The following is a description of a gene set: species: Mus musculus Any process that modulates the frequency, rate or extent of the chemical reactions and pathways resulting in the formation of glycogen. Mouse Gene Set: GOBP_REGULATION_OF_GLYCOGEN_BIOSYNTHETIC_PROCESS, and this is the list of marker genes: Ppp1cb, Ppp1r3d, Akt2, Gck, Dyrk2, Enpp1, Mtor, Sorbs1, Gsk3b, Ppp1r3g, Irs1, Pask, Esrrb, Ins1, Epm2aip1, Igf1, 1810024B03Rik, Gfpt1, Irs2, Pth, Ppp1r3a, Ppp1r3e, Inpp5k, C1qtnf2 (NCBI Gene Id 69183), Ins2, Ppp1ca, Akt1, Ppp1r3b, Ppp1r3f, Insr, Grb10, Prkag3, Ppp1r3c, Igf2